Given this list of marker genes SLC16A6, DERL3, DENND2C, PSMD11, PRIMA1, TLN2, B3GNTL1, KLF9, GFOD2, GFAP, ADAM19, FIGN (fidgetin, microtubule severing factor), MXD3, SEC24C, ZDHHC2, ARHGAP29, EHHADH, EIF2AK2, CAND2, RBMS2, ENPP1, NDUFS2, DNAAF11, OR9Q1, EPHB2, TNFAIP8L3, FMNL3, MAPKBP1, ZNF862, ZNF592, FAM161B, WIPF3, MMD, REEP3, CYP4V2 (cytochrome P450 family 4 subfamily V member 2), ARL8B, NCR3LG1, SLC25A46, TRABD2B, SNCAIP, KRT81, GPN1, MSI2 (NCBI Gene Id 124540), SYNJ2BP-COX16, SSH1, GOLM1, PCARE, LRCH2, DLK2, RAB14, MUL1, PLS1, HOXD1, TAT (tyrosine aminotransferase), SLU7, CCDC82, DCSTAMP, RTL5, SBF2, MTCL1, ATP1B2, PACS2, LRP2BP, CPNE9, SMARCD1, LARP1B, SH2D3A, COX16, DHX34, ZNF763, GSTK1, INPP5A, ADRA2A, UTP14C, LMBR1L (limb development membrane protein 1 like), FAM86C1P, EBF1, POGLUT1, C8orf58, LRRC8B, CLDN12, GTF2IRD2B, TM9SF4, HNF4A, SUCLG2, GTF2IRD2, SH3GL1, IGF2BP1, RAB10, NFIC, HM13, CCDC157, ERAP1, WNT5B, FA2H, ZSWIM5, PAFAH1B1, FCHO2, EBF4, SNX3, C5orf22, TMEM120B, AHR, RAB28, SPTLC3, SLC37A2, DYRK1A, ARHGAP19, IL17RE, TUBB4A, HLCS, ENTPD7 (ectonucleoside triphosphate diphosphohydrolase 7), COL4A6, ZHX2, ZNF565, HIF3A, PIPOX, CCND2, HGH1, MTMR1, CD209, CCDC177, SPINK7, SEC24A, YOD1, WNT4, SSTR2, PTPN2, TPP2, CACNA1C, PLK3, CMTM3, NTRK3, CD164, KLF7, USP22, RPTOR, MORN4, TMEM196, HEATR1, VSX2, here is a description of the gene set: Human Gene Set: MIR4316 Genes predicted to be targets of miRBase v22 microRNA hsa-miR-4316 in miRDB v6.0 with MirTarget v4 prediction scores > 80 (high confidence targets). species: Homo sapiens from publication Chen Y, Wang X (PMID 31504780)